Given this list of marker genes ZFP91 (NCBI Gene Id 80829), SNX32, CAMK4, FPR2, SSH2 (NCBI Gene Id 85464), CORO7, FADS1, CRTC1, TTC14, OSGIN1, KCNE3, RNF215, ULK1, MRPL14, SIPA1 (signal-induced proliferation-associated 1), MYO1F (myosin IF), SORL1, FCHSD1, PILRB, GNPDA1, MED22 (NCBI Gene Id 90955), ANKRD13D, DDX41, E2F6, TMEM86A, ARK2C, CYRIB, PREB, CIB1, DCAF8, LRWD1, ZMYND8, TAF6, ANKMY2, KCTD21, SESN1, SDHB, PPT1, CDPF1, ANAPC5, SFT2D2, HECTD3, FAM89B, ACP2, SGK1, CORO1A, IFT122, ZNF878, ADCY7, AOAH, LYL1 (LYL1 basic helix-loop-helix family member), FOXJ2, SZT2, TMEM64, SLC35C2 (solute carrier family 35 member C2), RNF166, NCBP2AS2, SDCCAG8, SH3BP1, ARMH3, VAMP4, ARHGEF6, NEU1, AASDH, CMTM3, TPRG1L, C16orf54, NBR1, NUAK1, FPR1, ARHGAP45, B4GALT1, ADIPOR1 (adiponectin receptor 1), LAMTOR1, UBAC2, CTNS (NCBI Gene Id 1497), GPR65, PTPA, TBC1D8, JADE2, RANBP10, CLN8, AP2A2 (NCBI Gene Id 25955), ZBTB48, IPP, PNKP, FERMT3, PIH1D1, FLYWCH1, NAGA, NISCH, SEC14L1, YPEL3, SERPINB8 (serpin family B member 8), CLPTM1, POMT1, ATP13A2, MFSD11, ADAM15, DAG1, GPSM3, COQ10A, SRBD1, TMUB2, MKNK2, ARRB2, N4BP2L1, NEK9, MINK1, MXD4, FUT11 (fucosyltransferase 11), LMO4, KIAA0930, GSTZ1, GBA2, ZDHHC9, PCYOX1, VTI1A, SKI, PTPN6, ABHD17A, ADAP1, FLI1, PPP1R21, ZNF467, FAM234A, CBR1, FAM168A, NDRG3, LDLRAD3, KCNAB2, CHST12, KIZ, RPS6KA1, DGKZ, GDPD3, RECQL, CCDC28A, ATP5F1D, PRKCB, ABCB10, ZNF229, LRRK1, GALT, ZNF571, MON1A, EPN1, DHRS3, PTDSS2, XPC (XPC complex subunit, DNA damage recognition and repair factor), XYLB, ACP6, TBL1XR1, RNF181, PDXK, AHRR, NPRL2, P2RX4, ABHD11, NTAQ1, LIN37, AP5M1, PLEKHG3 (pleckstrin homology and RhoGEF domain containing G3), RGL2, STARD9, PDPR, SERF2, AP4M1, NEK8, SLC43A2, TMEM94, ZFP64, DNMBP, STIM1, RTN3, SGSH, PLA2G7, TM2D2, MAST3, IFFO1, DHX34, UBE2E3, ORAI3, SLC45A4, CDH8, GGH, SLC25A39, TPGS1, HAGH, SLC38A9 (solute carrier family 38 member 9), APPL2, SLC25A40, TATDN3 (TatD DNase domain containing 3), CERK (NCBI Gene Id 64781), CC2D1B, WDR19, NATD1, VIPAS39, SIRPB1, RHEBL1, here is a description of the gene set: Human Gene Set: GSE46606_IRF4MID_VS_WT_CD40L_IL2_IL5_DAY3_STIMULATED_BCELL_DN Genes down-regulated in CD40L and IL-2 IL-4 IL-5 stimulated at day 3 B cell IRF4intermediate versus CD40L and IL-2 IL-4 IL-5 stimulated at day 3 B cell wildtype. from publication Ochiai K, Maienschein-Cline M, Simonetti G, Chen J, Rosenthal R, Brink R, Chong AS, Klein U, Dinner AR, Singh H, Sciammas R (PMID 23684984) Temporal analysis of B cell activation in vitro using CD40L and IL-2/4/5 cytokines in wild type Irf4+/+ B cells or in mutant Irf4-/- B cells harboring a tet-inducible allele of Irf4. IRF4 expression was restored, or not, in the Irf4-/- background by culturing in the presence of low or high concentrations of doxycycline. The results provide insight in the role of IRF4 expression levels in coordinating different programs of B cell differentiation. species: Homo sapiens